Given this list of marker genes PLCG1, KLF8, CCND1, CRK, ACTA1, MAPK9, ACTN1, JUN, RAP1B, PIK3R1, ASAP1, ETS1, SRC, ARHGAP35, FYN, RHOA, PAK1, ARHGAP26, MAP2K1 (mitogen-activated protein kinase kinase 1), GRB2, DOCK1, ITGB1, ITGB5, ARHGEF11, NCK1, RASA1, RAPGEF1, PIK3CA, PTK2, MAPK8IP3, ITGAV, GIT2, YES1, BMX, GRB7, TLN1, WASL, MAP2K4, ARHGEF7, MAPK1, MMP14 (NCBI Gene Id 4323), NCK2, SH3GL1, ITGA5, ROCK2, BRAF, RAC1, PTPN21, RAP1A, BCAR1 (BCAR1 scaffold protein, Cas family member), ARHGEF28, MAPK8, RAF1, PXN (NCBI Gene Id 80229), ELMO1, SOS1, CAPN2, RRAS, VCL, here is a description of the gene set: Signaling events mediated by focal adhesion kinase species: Homo sapiens from publication Schaefer CF, Anthony K, Krupa S, Buchoff J, Day M, Hannay T, Buetow KH (PMID 18832364) Human Gene Set: PID_FAK_PATHWAY